Given this list of marker genes MAP3K14 (NCBI Gene Id 9020), TOGARAM1, ABCB7, MTMR12, PRKAA1, IKZF4, NR2C2AP, MAFB, GSE1, CENPO, NRARP, ASXL2, MID1IP1, IER3IP1, HIVEP2, DENND10, MACIR, VCF1, MIGA1, DLL1, YTHDF2, BPTF, TRIM3, CUL3, AKAP1, FOXF2, WDR20, MFSD6, SPART, MAP3K12, PDGFRA, NCOA1, TPP1, NOCT, GADD45A, TIMP2, HBP1, SOX5, EPC2, ATG14, MAML1, ABCC5, MTF1, PTGFRN, NALF2 (NALCN channel auxiliary factor 2), SMAD5, PPP6R1, SPEN, IGF2BP1, RTN1, M6PR, NAA50, PEX5L, AGO4, ARID4B, LRRC37A11P, CSNK1G1, HECW2, SMARCD2, E2F7, NR3C2, CANX, CNIH1, INHBB, LDLRAD4, PRKD3, TBL1XR1, CAMTA1, PPP6R2, COL19A1, BMPR2, MYB, CLOCK, TMEM63B (transmembrane protein 63B), ACSL1, ST8SIA3, TRPS1, ADAM12, LCLAT1, SASH1, HABP4, G3BP2, TRIM2, SHANK2, USP6, USP32P2, TENT5B (NCBI Gene Id 115572), CCDC88A, TBC1D8, ZFPM2, MIGA2, FMR1, TERB1, MECP2, NPTN, GJA1, SLMAP, MIB1, TSPOAP1, ABCA1, BAHD1 (NCBI Gene Id 22893), NPTX1, WDFY3, RUNX3 (RUNX family transcription factor 3), SPTY2D1, ELK3, POU4F1, NSD3, ARGLU1, PTP4A1, ATG16L1, PITPNM2, TGFBR2, FSTL5 (follistatin like 5), MLLT10, RAPGEF4, SZRD1, POU3F2, KBTBD8, NRP2, RXFP2, SLC24A3, TSPYL2, BTBD7, RHOT1, NEUROG1, USP32, MPHOSPH9, NHLH2, NPNT, AGO1, ANKRD28, SAMTOR, AP1G1, SULF1, KIT, LNPEP (NCBI Gene Id 4012), PAK6, CALM2, BTF3L4 (basic transcription factor 3 like 4), MMGT1 (membrane magnesium transporter 1), USP33, UBE2D1, CLIP1, LRCH2, CHMP3, CCDC126, LRP8, SLC9A2, ZNF282, ATRX, CHST1, TNRC6A, MYT1, PAFAH1B1, ARK2C (arkadia (RNF111) C-terminal like ring finger ubiquitin ligase 2C), ST18, RAB5B, SIK1, EDA, BAZ2A, PHAF1, KLF13, KDM2A, ZFYVE9, ZCCHC14, JAKMIP1, BRWD1, MLEC, RXRA, RAB5A, S1PR1, MEMO1, ENPP5, MTLN, CSF1, NAA30, SMC4, HOXB3, RAP2C, PHACTR2 (NCBI Gene Id 9749), LIMD2, ARHGAP12, VGLL4, CNOT4, ATP11A, USP48, SOX21, ROBO2, ZNF784, RELCH, TP53INP1, WDR47 (NCBI Gene Id 22911), MDGA2, BLCAP, ACBD5, SOCS5, MEX3D, NIPA1, PPARG, RNF145, UBE2D2, UCP3, NEUROD1, CHD9, FAM53B, SKP1 (S-phase kinase associated protein 1), N4BP1, MPPED2, STIM2, ZNF609, ARHGEF12 (Rho guanine nucleotide exchange factor 12), STX6, RAI2, ITPK1, FASTK (Fas activated serine/threonine kinase), PIK3IP1, DCBLD2, RBM33, CNOT7, TTYH3, BHLHE41, ZEB2, EPS15, ZNF711, DICER1, SNAP25, ZFYVE26, HOXA5, SNIP1, ADCY2, CREB5, PAN3, KMT5B, ZNF800, BACH2, WNK3, NHS, HOXA3, SUV39H1, NBEA, FAM234A, RBBP8, PFKFB3 (NCBI Gene Id 5209), SH3D19, AKAP7, INO80, DOCK3 (NCBI Gene Id 1795), ATP6V1B2, WNT2B, CMPK1, ULK2, LRP4, TESK2, MARCHF2, RALBP1, SPOPL, R3HDM1, PTPRG, PHF12, FAM20B, MB21D2, ATRN, PUF60, NPEPL1 (aminopeptidase like 1), SOCS6, DNAJC16, ZNF3, ERBIN, ACVR1, GPATCH8, SNX5, SLF2, ACSL4, BIRC6, PMEPA1, DPYSL2, ATP2B2, OGT, SPHK2, DSEL, VPS37B, RNF38, PGM2L1, EMX2, GRM7, TMEM50B, EFNB2, SCRT1, SPATA2, LONRF1, PTPRM, ARFIP1, ZBTB4, CLTC, TENT2, ADAMTS18, ABHD3, ZFC3H1, PLAA, SNX2, DENND1A, PSAP, MAF, MAP4, BTG1, MAT2B, ITPR1, CDK19, IRF1, TAF4, WNT1, MEOX2, MED12L, CLCN5, CEP120, VGLL3, KMT2A, CSMD1, LRIG1 (NCBI Gene Id 26018), SYBU, AGFG1, LCORL, SKIDA1, STC1, DIP2A, VPS37A, ADCY1, SLAIN1, CNOT6, B4GALT5, PPP6R3, PIGA, EREG, PHF3, CD69, NDEL1, KLHL20, SFMBT1, SNPH, NME7, PRR5L, MIER1, MAP3K9, HECA, ERBB4, MDFIC, TSC1, MBNL1, PLCB1, ATXN1, CEP170, BTAF1, DDX6, RAB30, WDR1, RASSF1, TNRC6B (trinucleotide repeat containing adaptor 6B), GDA, NRP1, ZBTB18, TARDBP, ROBO1, ZFP91, PSD, SMOC2, BTBD3, RAB34, GPCPD1, MLLT6, LDLR, ANKRD12, PELI1, CPEB4 (NCBI Gene Id 80315), DYNLL2, EXOC5, MIER3, NRBF2, FBXO28, APPL1, STIMATE, ARHGAP35, RUNX2, WEE1, ARRDC3, SNX27, NPAT, ZNF217, OTUD4, GOLT1B, MAPRE3, DNM2, GAP43, DENND10P1, RASD1, ARHGAP21, SMOC1, ESR1, CYLD, SLC44A1, STARD13, TP63, SOX4, QKI, ARHGAP1, here is a description of the gene set: Human Gene Set: TTGCACT_MIR130A_MIR301_MIR130B studied in species Homo sapiens Genes having at least one occurence of the motif TTGCACT in their 3' untranslated region. The motif represents putative target (that is, seed match) of human mature miRNAs hsa-miR-130a, hsa-miR-301 and hsa-miR-130b (v7.1 miRBase).